Given this list of marker genes GABRG3, HTR3A, CHRNB1, ASIC2, GABRR1, GABRP, GABRG2, P2RX4, CHRNA2, TRPC3, P2RX3, GLRA1, GABRA5, GLRB, CHRNA4, SCNN1A, CHRNB2, GLRA2, CHRNB3, GABRA2, RYR1, GLRA3, GABRD, CHRNE, ATP6V1B1, CHRNB4, GABRB3, here is a description of the gene set: Ion channels. species: Homo sapiens Human Gene Set: MODULE_214